Given this list of marker genes Bnip3, Mff, Inf2, Mief2, Ddhd2, Spire1, Mapt, Pink1, Irgm1, Ralbp1, Mul1 (NCBI Gene Id 68350), Stat2, Marchf5, Ppargc1a, Prkn (NCBI Gene Id 50873), Fis1, Mcu, Igtp, Pgam5, Aurka, Kdr, Cyrib, Mfn1, Myo19, Rala, Mfn2, Tmem135, Mief1, Dnm1l, Ddhd1 (DDHD domain containing 1), Mir539, Irgm2, Dcn, Dhodh, 4930550C14Rik, Vps35, Carlr, Pparg, here is a description of the gene set: Mouse Gene Set: GOBP_REGULATION_OF_MITOCHONDRIAL_FISSION Any process that modulates the rate, frequency or extent of mitochondrial fission. Mitochondrial fission is the division of a mitochondrion within a cell to form two or more separate mitochondrial compartments. species: Mus musculus